The following is a description of a gene set: part of: Biosynthesis of DPAn-3 SPMs Reactome Pathway: Biosynthesis of DPAn-3-derived 13-series resolvins Neutrophils adherence to the vascular endothelium is a critical and early event in the innate immune response to injury or invading pathogens. Studies of the lipid fraction from neutrophil-endothelial cell cultures resulted in the discovery of four novel specialised proresolving mediators (SPMs). Results from LC/MS-MS metabololipidomics using a chemically-synthesised precursor (13(R)-hydroxy-DPAn-3) identified four mediators generated from this precursor.<br><br>The polyunsaturated fatty acid (PUFA) ω-3 cis-7,10,13,16,19-docosapentaenoic acid (DPAn-3) is an intermediate in the biosynthesis of docosahexaenoic acid (DHA) from eicosapentaenoic acid (EPA) and is also a precursor for the production of novel bioactive mediators. DPAn-3 can form this precursor when acted upon by cyclooxygenase 2 (COX2). Thus these novel 13-series resolvins (RvT1-4) originate from DPAn-3. In E. coli-infected mice, RvTs accelerated resolution of inflammation and increased survival. RvTs also regulated human and mouse phagocyte responses, stimulating bacterial phagocytosis and regulating inflammasome components. The biosynthetic routes of these RvTs are described here. RvT formation requires neutrophil-endothelial cell interaction and is thought to proceed via a two-step process; COX2 hydroxylates DPAn-3 to 13(R)-DPAn-3 which trafficks to adjacent neutrophils where it is lipoxygenated by 5-lipoxygenase to RvT1-4. species: Homo sapiens, and this is the list of marker genes: ALOX5